Given this list of marker genes DICER1, SETMAR, MRE11, DCLRE1C, MBD4, APLF, BIVM, RAD51C, TEFM, DNASE1L3, N4BP2, ENDOG, EME1, RAG1, DNASE1, SLX1A, APEX1, SLX1B (NCBI Gene Id 79578), ERCC5, EME2, EXOG, XRCC3, DNASE2, MGME1, DFFB, ANKLE1, FEN1, ZRANB3, ENDOV, GEN1, ERCC1, RBBP8, RPS3, FAN1, DNA2, DNASE1L1, MUS81 (NCBI Gene Id 80198), ASTE1, DNASE2B, ERCC4, EXO1, RAD50, DNASE1L2, XRCC1, here is a description of the gene set: studied in species Homo sapiens Human Gene Set: GOMF_DNA_ENDONUCLEASE_ACTIVITY Catalysis of the hydrolysis of ester linkages within deoxyribonucleic acid by creating internal breaks.